Given this list of marker genes GNS, SMAD4, RCC1, SULT1A3, SULT1A4, CD34, here is a description of the gene set: Human Gene Set: GOMF_SULFATE_BINDING Binding to sulfate, SO4(2-), a negatively charged small molecule. studied in species Homo sapiens